Given this list of marker genes Nolc1, Naca, Jun, Edf1, Drap1, Nkx2-1, Taf12, Gtf2a1, Ctdp1, Rnf4, Ruvbl2, Psmc1, Thra (NCBI Gene Id 319227), Nr3c1, Taf1, Gtf2f1, Atf4, Nr3c2, Runx2, Ercc4, Optn, Rela, Znhit6, Hnrnpf, Foxf2, Trp53, Tcf4, Taf13, Psmc5, Dr1, Bcl10, Med1, Bdp1, Ercc1, Gtf2a2, Gtf2b, Gtf2e2, Utf1, Crebbp, Ahr, Esr1, Hsf1, Cand1, Brf1, Ar, Fbl, Cand2, Nop58, Hnrnpu, Psmc2, Ruvbl1, Yeats2, Thap7, Taf11, Taf7, Mtor, Brf2, Polr1e, Zbtb43, Tbp, here is a description of the gene set: Mouse Gene Set: GOMF_GENERAL_TRANSCRIPTION_INITIATION_FACTOR_BINDING species: Mus musculus Binding to a general transcription initiation factor, a protein that contributes to transcription start site selection and transcription initiation.